Given this list of marker genes KRTAP3-1, CHMP4C, TUBA1C, LRPPRC, MAP2K1, KRT78 (keratin 78), LCP1, TUBB4A, RAC1, MAP1LC3B2, KRTAP23-1, MAP6, KRTAP3-2, TPM4, COL6A5, CAMSAP2, MYL6B, THSD4, TTN, KRTAP10-3 (NCBI Gene Id 386682), ITGB1BP2, LIMA1, SPMIP6, KRT74, KIF5B, TTLL9, ENKUR, C10orf71, POTEF, KCNN3, KRTAP9-9, MAP9, CTTN, TRIM63, MYO6, FYN, NUDC, HAUS5, EML2, CCT4, CSPP1, SELENOS, DNAJB4 (DnaJ heat shock protein family (Hsp40) member B4), CDK5, NEFL, MYO5A, SSNA1, SHROOM2, TNNT1, SPACA9, DCTN4, NEXN, KLHL21, ADAMTS10, TUBB, ACTG1, EFHC1, KIF3B, MAPRE2, GOLGA2, KRT82, TPGS2, TNNI2, MTCL2, NUMA1, DPYSL3, CFAP52, CLASP1, DYNC2H1, ARL3 (ADP ribosylation factor like GTPase 3), KIF2A, RHOQ, KRTAP11-1, TUBB8, KRT72, KIF23, KIF4A (NCBI Gene Id 55595), TSC1, DNM1L, KRTAP21-1, TMOD2, DNAH8, EVPL, TUBGCP5, ACTA2, AURKA, ARFGEF2 (NCBI Gene Id 10564), TBCB, KIF18A, PKP1, KRTAP13-3, KCNJ8, RAC3 (Rac family small GTPase 3), DISC1, KRTAP5-5, DSP, KRT14, KRTAP5-3, NEK6, MACF1, ZNF804A, DNAH6, MAP10, HSPH1, ODF1 (NCBI Gene Id 4956), FAM110C, MT3, WDR47, CYLD, CACNA1D, KRTAP12-4, KRTAP29-1, MAP3K11, CFAP45, MAP1B, LTBP4, SIMC1, TUBA4A, CHMP4A, CD2AP, KIF5A, TTLL6, DYNLT2, KATNAL1, TPM2, KIF2B, PIERCE2, CRHBP, BICD1, KIF13A, HAUS6, CCT2, SPAG8, KRTAP20-1, HID1, CLIP3, KRTAP9-7, SLC1A4, KRTAP13-1, MAPRE3, ACTG2, RAB3D, RASSF3, FXR1, ACTN1, COBL, KRTAP19-5 (NCBI Gene Id 337972), TEKT1, DMD, CAV3, TTL, SPMIP10, PAWR, FKRP (fukutin related protein), POTEJ, BCL2L11, CENPE, KNSTRN, KRTAP5-11, MYOM1, KIF21B, TPPP3, MAPRE1, DLG1, CFAP144, MID1IP1 (NCBI Gene Id 58526), SIRT2, CTPS1, SYNJ1, SRI, DYNLL2, CLASP2, SHANK2, KRT71, JPH2, DYNLRB1, ARPC3, CCT7 (chaperonin containing TCP1 subunit 7), DUSP21, REEP4, GAS2L1, CFAP141 (NCBI Gene Id 388701), KIF18B, KIF5C, CHMP6, COL5A3, TEKT2 (NCBI Gene Id 27285), KRTAP4-8, CHMP1B, DYNLT1, TCAP, SCN5A, SCYGR8, CYP2A6, KRTAP4-11, COL10A1, HLA-DRB1, RP1, RP1L1, CFAP95, ANKRD23, FBXO32, CHMP4B (charged multivesicular body protein 4B), NAV1, ABRAXAS2, SLAIN1, KRTAP19-4, KRT36, TEKTIP1, KRT31, DEK, COL28A1, KRTAP21-3, TUBB1, CAMSAP3, NUSAP1, KCNE1, KRTAP13-4, ILK, COL27A1, LMAN1, MYL1, KLHL41, KRTAP5-8, COL6A6, SRC, COL8A1, DNAH10, LMNB1, DNAH9, EML6, CLIP4, COL2A1, SHROOM1, MYH13, BFSP2, ATAT1, KIF21A, TNNC2, CFAP206, CKAP2, ZW10, GFAP, TUBB2A, ATP2A1, TEKTL1, KRT81, MID1 (NCBI Gene Id 8230), ARF1, KRTAP27-1, ESPN, TUBA8, CLIP1 (CAP-Gly domain containing linker protein 1), FSD1, TUBA3D, KRTAP6-3, FGF13, TMOD4, CCSAP, PYCARD, RUSC1, KCNAB2, MYLK2, CFAP161, KRT34, KIFC3, KRTAP19-8, FBXO22, ACTB, COL6A2, CDK5R1, TUBG2, TWF1, CSRP3, RTN2, PDLIM7, KRTAP4-9, KIF22, MYH4, ARHGEF25, SERP1, CLTC, DNAH7, AKAP4, KRT20, KRTAP1-5, DYRK1A, SKA2, CSNK1D, KRT15, INA, EIF3A (eukaryotic translation initiation factor 3 subunit A), DNAH2, KRTAP20-2, SYBU, PACRG, PNN, SEPTIN9, CCDC181, MYOZ2, IQGAP1, TUBB3, ACTBL2, OBSCN, CEP57L1, KRTAP5-10, CENPJ, KRT3, RASSF5, COL8A2, PLK1, GRAMD2B, BBLN, TTLL11, DNAH14, ANK2, KIF14, KLC1, KIF1A, KRTAP9-8, KRTAP9-1, PDLIM2, KRTAP22-1, MYH2, MAP7D2, MFAP4, KCNN1, PPP3CB (protein phosphatase 3 catalytic subunit beta), TUBD1, POLB, WDR90, CACNA1C, CDK2AP2 (NCBI Gene Id 10263), INVS, KRTAP20-3, MAP1LC3C (NCBI Gene Id 90303), MATCAP1 (NCBI Gene Id 654077), KRT79, BCAS3, TUBB8B, DYNC1LI2 (NCBI Gene Id 1783), LZTS2, MYH8, KLC4, CASQ1, TMEM214, KRTAP19-3, PBXIP1 (NCBI Gene Id 57326), CHMP3, COL1A1, CSNK1A1, KIFAP3, COTL1, CFAP90, MARK2, KRTAP17-1, KRTAP10-6, KRTAP5-9, PPP1R12A, SMPX, CFAP210, DPP9, PIERCE1 (piercer of microtubule wall 1), DCXR, TTLL3, DNAI1, PDLIM4, DYNLT3, ACTL8, TUBB6 (tubulin beta 6 class V), KNTC1, DVL1, DYNLRB2, KRTAP5-1, MYOZ1, TTLL8, KRT2, LRRC39 (leucine rich repeat containing 39), FBXL22, MYH14, POLR2M, FKBP4 (NCBI Gene Id 2288), POTEE, SHROOM4, RMDN2, KRT86, TOGARAM2, PDE4B, KRTAP25-1, HOOK3, MYH6, MTMR12, TTLL4, MYBPH, TPPP, SPMIP9, TNNI1, NOS1, MID2, CASP1, SAXO2, ACTN2, PPP3CA, EZR, SPTBN1, STYXL2, CAVIN4, KIF27, STUB1, DCDC2, PAK1, ACTC1, MAP1S, PARVB, SCO1, TNK2, CEP170, SLMAP, APPBP2, CCDC57, ABRA, TUBAL3, KIF25, KRTAP2-3, CHMP2A, KY, SPAST, KLHL40, HRC, KRT73, KRT28, PYROXD1, FLNC, MMP2, SYNE1, CCT6A, MYL4, SORBS2, ANKRD1, TMEM232, REEP1, COL5A1, COL4A2, RCC2, TTLL5, DCDC1, CEP170B, SH2B2, KRTAP19-1, KRT8, ALDOA, COL4A4, TBCE, ODAM, NCKAP1, CTSH, COL11A2, BIRC5, SCYGR2, DIAPH2, UPP2, MYO18A (NCBI Gene Id 9799), FBLN1, KRT35, CHMP4BP1, MYBPC2, TUBGCP2, BAIAP2, CDK5RAP3, AURKB, CIMIP2A, DAG1, KRT40, WIPF1, SMN2, SCYGR4, KATNB1, CEP162, HOMER1, NINL, CKAP5, FRG1, KRTAP24-1, GTSE1, SKA3, DNAH5, MYBPC3, SCYGR3, ANXA1, MYZAP, ACTN4, NICN1, KIF1C, KRTAP13-2, CFAP68, TUBA3C, TUBGCP3, BFSP1, DCDC2B (NCBI Gene Id 441881), IFT70B, SNPH, FBLN5, TUBB2B, KRTAP22-2, JPH1, KRTAP5-2, KIF6, YES1, LUM, RIBC2, KRTAP10-1, KRTAP9-2, PPP1R12B, NIN, TRIM55, CLIP2, ASPM, CTNNB1, TUBA1A, TRIM54, FBP2, CIMAP1A, CSTPP1, MTCL1, MAPT, NME7, PECAM1, SAXO1, KIF1B, KRTAP9-4, KRTAP1-4, BLOC1S6, AMOT, KRT33B, NARF, KRTAP1-1, KRTAP8-1, TUBB4B, FBXW11, TUBA4B, ZWILCH, SVIL, ARL6, FLNB, LRRC10, HSPB1, HAUS2, GAS8, DNAJA3, GABARAPL1, NEFH, CHMP1A, SHTN1, KRTAP4-4, MYOT (NCBI Gene Id 9499), FBN3, RNF4, KRTAP12-1, MYL12B, KRT6A, DYNC1I1, STAU2, SNTB2, MYBPHL, CLDN11, CIMAP1D, CALM1, KRTAP19-2, FHL2, SPRY2, LMNB2, MISP, SPMIP11, MYL7, KIF9, HOOK1, KIF26A, PCNT, HOOK2, CSRP1, KIF16B, KIF26B, INO80, KRTAP4-12, TNNI3, GAS2L2, FMN1, KRT19, CORO1C, VCL, NDRG1, KIF20A, KIFC1, KRTAP4-2, CSRP2, BOD1, LRRC49, ACKR2, GAS2L3, MYO3A, CLMP, COL4A5, NEK2, NDEL1, TBCC, LMNTD2, XIRP2, KCTD6, CCT5, SDC4, KRT38, ADAMTSL5, VPS18, COL5A2, CALD1, ELN, CFAP77, MNS1, KRTAP10-7, ANKRD2, KRT26, KRT24, LMOD3, OBSL1, JUP, CFAP53, COL4A6, CCDC66 (NCBI Gene Id 285331), KRT83, MTM1, KRTAP4-1, VIM, ATP2B4, WAS, EML3, ABI2, ZNF207, KRTAP26-1, EPPK1, KRTAP10-2, FAM161B, LMOD2, CIMIP2B, KIF3A, KRT39, VMAC, TTLL7, NCKAP5, KRT37, DNM3, TUBG1, CAPN6, DCTN1, IFFO1, KIF2C, EIF6, KRTAP10-5, SLC8A1, MAP2, GABARAP, MYL3, KIF7, MYOZ3, MYH3, REM1, COL4A1, TCHP, MEFV (MEFV innate immunity regulator, pyrin), KATNAL2, ENKD1, KRTAP15-1, DLGAP2, RCSD1, POTEKP, SYNE2, PDLIM1, DCTN2, KIF24, SYNPO, PARVA, GDPD2, MICAL1 (NCBI Gene Id 64780), TUBGCP6, PRPH, BCL10, RYR3, CFAP126, FHOD3, TUBA1B, NES, NDE1, TPM1, HAUS3, KRTAP9-3, FAM83H, DNAJB6, COL4A3, CEP295, CASP14, NOS1AP, DNAH17, KRT10, MX1 (MX dynamin like GTPase 1), SYNC, MAP4 (NCBI Gene Id 4134), KEAP1, TPPP2, SARM1, CTPS2, KIF12, PGM5 (NCBI Gene Id 5239), TMOD1, CCT3, DYNLL1, SMTNL1, SAXO4, COL6A3, AURKC, KIF4B, SQSTM1, KRT84, MYBPC1, EFCAB6, IQGAP2, PPP2R5A, EML4, GAS2, IFFO2, KATNA1, MYH7B, DNM2, KRT4, FHDC1, MYH7, TBCD, DST, TPX2, KRTAP4-16, KRTAP3-3, KRTAP5-7 (NCBI Gene Id 440050), TNNT2, OPA1, MYPN (NCBI Gene Id 84665), LMNA, SPECC1L, FBN2, NEK7, CACNA1S, NRAP, HCK, SYNPO2, KAT2B, CHMP5, INCENP, HAUS4, KRT76, APC, FERMT2, SYNM, CHMP2B, DNAH3, KRTAP19-6, TUBE1, DNM1, EFEMP2, SAA1, CRYAB, DNAL4, POTEI (POTE ankyrin domain family member I), LMNTD1, MYH9, GGPS1, MTA1, SYNPO2L, KRTAP2-4, DYNC2LI1, KIF17, SPAG6, SCYGR7, KRTAP12-2, COL1A2, KIF28P, CFAP276, ENO1, MYO1B, PRKD1, KRT25, RMDN1 (NCBI Gene Id 51115), SCYGR1, STMN1, TEKT5, CASQ2, APC2, DNAH11, RSPH1, CHMP7, KRT87P, EML5, GPER1, AKNA, PARP4, KIF19, SCN8A, MYH1, CFL2, CAB39, CAPN3, ARHGAP4, MAP7, CORO1A, KIFC2, CORO1B, SLC8A3, MAP6D1, SLC2A1, KIF13B, SPTBN4, MYOM3, RAB11A, DYNC1LI1, TWF2, AIF1, KRT16, KRT18, DMTN, KRT1, KRTAP20-4, SCO2, KRTAP5-4 (NCBI Gene Id 387267), CFAP20, SHROOM3, RADIL, PLS3, ADORA2A, TMOD3, PLS1, ANK1, CAMSAP1, KIF3C, TPT1 (tumor protein, translationally-controlled 1), GJB6, BIN1, HAUS1, REEP3, KLHL22, AFAP1, KLC2, TCP1, WHRN (whirlin), PALLD, DYNC1I2, TBCA, SPAG17, CIMIP2C, SCYGR5, CCT8, DCX, KRT27, KRT7, IDO1, TNNC1, SPMIP8, MYOM2, KRT33A, DNAH12, MYO9A, FKBP1B, MTUS2, MAP1LC3B, PSRC1, KRTAP4-3, FEZ1, NRP1, FHL3, MFAP5, CMYA5, KRT6C, KRT6B, AVIL, RGS14, KRT75, FIGN, MTUS1, KRT80, KRTAP10-12 (keratin associated protein 10-12), DCDC2C (NCBI Gene Id 767840), ODF2, HDAC6, IFT70A, POF1B, KRTAP4-6, AK1, CALM2 (calmodulin 2), LMOD1, TCP11L1 (NCBI Gene Id 55346), NEB, DYNC1H1, KRTAP16-1, AIF1L, REEP2, IGFN1, SMN1, MYH15, KRTAP19-7 (NCBI Gene Id 337974), DIAPH3, TEKT3, NCKAP5L, KIF15, FKBP1A, HNRNPU (heterogeneous nuclear ribonucleoprotein U), KRTAP7-1, MDM1, TEKT4, ARHGAP6, MX2, CFAP96, EMD, RASSF1, ACTA1, CEP57, SCN3B, UNC45B, ANK3, MYO18B, KRTAP2-1, PVALEF, TPM3, HTR2A, MAP1A, MYL11, PPL, PAFAH1B1, KRTAP10-9, TOGARAM1, CDK5RAP2 (NCBI Gene Id 55755), NPNT, TUBGCP4, SCYGR6, MYL2, SCTR, MYOD1, INF2, KRTAP10-10, SRPRB, DNAL1, FLACC1, MYO9B, KCNA5, DES, RYR2, KRTAP10-11, EFHB, KIF11 (NCBI Gene Id 3832), CAPZB, HAUS8, MFAP1, KRTAP4-5, LTBP1, TUBA3E, KRT5, FLNA, MFAP2, HAUS7, BMP10, KPTN, NCKIPSD, PLEC, TEK, MAP2K2, FAM161A, PRC1, KCNN2, KRTAP1-3, TRIM32, ACTN3, SCYGR10, KRTAP21-2, KRT13, KRT23, FAM110A, PTPN20, KRT222, DUSP22, EML1, MYO1A, SLC4A1, PDLIM5, KRTAP10-8, KRT32, KIF20B, FBF1, STIM1, PRICKLE4, ARHGAP18, SCYGR9, SLAIN2, COL11A1, DNAH1, CARMIL1, CALM3, RYR1, NBR1, ABCC9, LUZP1, TLK2, KRT77, NAV3, BAG3, FHL5, MYO1C, JAKMIP1, KRT17, TTLL13, KRTAP12-3, SPAG5, DIAPH1, LDLRAP1, MYL9, ASB2, DDX6, PDLIM3, SCN1A, EFHC2, DPYSL2, KRTAP9-6, MYH11, KRT9, KRT85, COL3A1, PSMA6, BAG2, AHNAK, TTLL1, TRPV4, HABP4, KRTAP6-2, DNAI2, TNNT3, KRT12, NEBL, RAC2, GLRX3, TUFT1 (tuftelin 1), S100A1, KRTAP6-1, LDB3, SPECC1, MYH10, CFAP107, PDE4DIP, CUL3, RIBC1, GABARAPL3, CNP, FBN1, ADPRHL1, BEX4, PKP2, CDK1, RMDN3, JAM3, COL6A1 (NCBI Gene Id 1291), SNCA, TPGS1, SKA1, SPEF1, MICAL2, KLC3, KRTAP10-4, MYL5, NEFM, ARHGEF2, KRTAP5-6, WHAMM, RACGAP1, MAP1LC3A (microtubule associated protein 1 light chain 3 alpha), here is a description of the gene set: studied in species Homo sapiens Human Gene Set: GOCC_SUPRAMOLECULAR_POLYMER A polymeric supramolecular structure.